Given this list of marker genes Prkdc, Foxn1, Spn, Cd69, Otud5, Braf, Tnfsf18, Rag2, Cyld, Il4, Brd4, Il23a, Ep300, Il6, Il7, Loxl3, Brd2, Tox, Foxp3, Stat6, Mtor (mechanistic target of rapamycin kinase), Opa1, Ctsl, Lgals1, Bcl2, Trp53, Batf (basic leucine zipper transcription factor, ATF-like), Scart2, Kctd9, Irf4, Rhoa, Shh, Stat3, Ly9 (NCBI Gene Id 98478), Tgfb1, Tbx21, Il6ra, Slamf6, here is a description of the gene set: The process in which a lymphoid progenitor cell becomes committed to becoming any type of T cell. Mouse Gene Set: GOBP_T_CELL_LINEAGE_COMMITMENT studied in species Mus musculus